Given this list of marker genes SETBP1, SLC4A8, HEYL (NCBI Gene Id 92408), ARID2, PAXBP1, LAMC1, BRD4, CAPN6, XYLB, LSAMP, GRIK3, NFIX, HLA-DQA2, RPRD2, GFRA2, SDK2, HOMER1, KDM2A, ADAM12, TRIM66, MTCL2, PDX1, GALP, NAV1, TMED10, SPTBN4, KAZALD1, EZH1, SERPINA6, ISLR2, FAM169BP, CXCL12, SIX3, HOXC4, GPR62 (G protein-coupled receptor 62), KLK4, TNS1, ISM2, STK40, LMO7DN, LYSMD3, CHRDL1, TRIM67, SHISA6, BICDL1, EPSTI1, LRATD2 (LRAT domain containing 2), FAM78B, ZNF436, PDE4A (phosphodiesterase 4A), KCND1, AHDC1, PRIMA1, RAD54B, CHMP1A, SERP2, SEPTIN3, SP2, TPCN1, EEIG1, CPLX1, DPAGT1, LHFPL4, RIBC1, SDK1, TIMP3, HNF4A, CCDC28A-AS1, VAMP2, CFAP77, TANC2, ZC3H12A, ABCG4, BCAM, SKI, CDX1, MTSS2, UPK1A, CNNM4, OTP, PPP1R12B, NBR1, GSE1, PFKFB3 (NCBI Gene Id 5209), IKZF4, PLA2G3, SERPINA1, GPR107, CD34 (NCBI Gene Id 947), C1orf226, CLSTN1, GTPBP1, CORO2B, SOCS7, DBNDD2, SLC38A7 (NCBI Gene Id 92914), RAD51B, HOXB5, TMEM26, GLT6D1, MYCN, ADGRG5, PLP2, C5AR1, FAM78A, ASB16, POM121, PCDHGA12, KLK12, PDE6D, KPNA3, SYPL2, RND2, RUFY4, PSD2, SCFD2, KIAA1671, C3orf80, RAB5B, RBM20 (NCBI Gene Id 282996), KPRP, N4BP3, CSF1R, KAT7, LMLN, KIRREL2, ZNF396, SP6, KMO, ARID1A (NCBI Gene Id 8289), CTDSP1, GABRA3, MDM1, KIRREL1 (kirre like nephrin family adhesion molecule 1), NOVA2, TLCD3A, FBXO21, CACUL1, COL4A6, CNTFR, CNTNAP1, TCF4, GAB2, VPS25, DENND1A, WDR59, ST3GAL2, DLX3, LRP4, ARAF, COX10, YWHAG, COL27A1, RPH3A, ZNF444, NDEL1, FXYD3, INO80D, TEX2, TMEM265, DGKD, ELK1, GLG1, CD164L2, LINGO1, GRIN2B, FAM117A, ZNF710 (zinc finger protein 710), ANKRD40, POU2F2, G3BP2, UNC5B, SGPP2, CACNG7, CEACAM6, ZNF784, POLR2F, NDUFA4L2, PTPRT, PTK2B, PRLR, LAT2 (NCBI Gene Id 7462), CADM4, PLPBP, SYNE3, LHPP, LRRC8A, SLC18A3, CCL4, AGO1, ATXN1L, URM1, EN2, ZIC3, SPRR4, HDAC5, C11orf87, TESMIN, SHANK2, DNM2, ZDHHC9, MYO1A, ZBTB45, NUTF2, PML, GPATCH1, SEC61A2, PSMD11, HLA-DQA1, here is a description of the gene set: Genes predicted to be targets of miRBase v22 microRNA hsa-miR-11181-3p in miRDB v6.0 with MirTarget v4 prediction scores > 80 (high confidence targets). Human Gene Set: MIR11181_3P species: Homo sapiens from publication Chen Y, Wang X (PMID 31504780)